Given this list of marker genes HSP90AA1, CLU, DNAJB1, DNAJB8, MAPT, SNCAIP, MARK2, HSPA1A, UBD, HSPA1B, MFSD8, PPP2CB, BAG5, IFNB1, APOE, TRIM37, EPG5, DNAJB2, SACS, PSMC5, DNAJB6, HDAC6, HSF1, HSPA2, DNAJA4, PSMC6, VCP, MIR219A1, SORL1, BAG3, DYRK1A, PRKN, here is a description of the gene set: The aggregation, arrangement and bonding together of a set of components to form an inclusion body. Human Gene Set: GOBP_INCLUSION_BODY_ASSEMBLY studied in species Homo sapiens